The following is a description of a gene set: Human Gene Set: chr5q22 species: Homo sapiens, and this is the list of marker genes: ENSG00000289497, TICAM2-AS1, RPS3AP21, STARD4-AS1, TMEM232, TRIM36-IT1, RNU2-49P, TMED7-TICAM2, KCNN2, LINC01957, CTNNA1P1, RNU4ATAC13P, ENSG00000207177, XBP1P1 (X-box binding protein 1 pseudogene 1), EPB41L4A-DT, YTHDC2, ZRSR2P1, ENSG00000248709, TMEM183AP6, HMGN1P13, AP3S1, HMGN1P14, WDR36, H3P24, BCLAF1P1, AK3P4, RN7SKP57, APC, HMGB3P16, ATG12, TICAM2, MIR548F3, NREP, DCP2, LINC02200, REEP5, SLC25A46, PGGT1B, TSSK1B, NREP-AS1, CAMK4, TRIM36, CBX3P3, RNU6-482P, EPB41L4A-AS1, EPB41L4A, SRP19, TSLP, CCT5P1, SNORA13, FEM1C, RN7SKP89, MCC, HMGN1P15, CCDC112, CDO1, TMED7, STARD4